Given this list of marker genes ZNF629, ERP44, UBXN2B, POP4, ZNF623, KIAA0753, GRM2, NDUFB6, NOL4, ASMTL, SAPCD1, XCL1, DUSP1, PDPN, RALGAPB, PSMA7, TNFAIP1, PEG10 (NCBI Gene Id 651242), UPK3A, COMT, PRKCH, RHBDD3, HLCS, RFXAP, LILRB2, RLIG1, RRAS2, NDUFS6 (NCBI Gene Id 4726), CEACAM7, GPSM3, ZFP36 (NCBI Gene Id 7538), DNAH17, GAPVD1, DOT1L, SRP9, RHOG, MUC6, COQ2, ATP5PO, BBC3, MFN2, FKTN, HMGB2, CNPY3, ATP5MJ, RPL13P5, FGF1, PBX2 (NCBI Gene Id 5089), LDHB, OVOL2, ATXN3, MSX2, GLRA2, PTPRN2, PRDX2, MCAT, IMPA2, ZNF271P, GLMN, NUP133, NDUFB1, TMPRSS11D, IQSEC2, CRYAA, STEAP1, HDAC2, SLC35A2, APOBEC3B, DOK5, CDK18, CKAP5, PTPRCAP, GNRH2, SLC26A10P, ARHGAP5, HNRNPM, MUC5B, IFT25, CTRC, PYGM, ASB9, CILK1, DGAT1, ORC2, PLS3, OVOL3, RAC3, RAP1GDS1 (NCBI Gene Id 5910), FUT1, RAG2, FMO5, H3C4, MYO6, ZNF92, MIR124-1HG, FLRT1, CAPN15, SPAG1, GOLIM4, RIDA, ALB, STOM, KRT31, SLC4A7, PLPP2, DLEC1, IRAK3, GUCY2D, FDPS, APOBEC3F, ZNF41, KRT34, KTN1, CUL4B, INPP4B, AIF1 (allograft inflammatory factor 1), LMO2, SMARCA5, TSC22D3, HSD11B2, BTN3A1 (NCBI Gene Id 11119), PLCH1, POU3F2 (POU class 3 homeobox 2), GPR15, TGIF2, CLASP1, AMHR2, IMPDH2, H1-2, TPM1, ANAPC5, ZNF142, RAB31, GIP, RGS2, CD1D, NAP1L3, HERC4, MAPT, RBMX2, SEPTIN11, DCBLD2, KCNF1, RUSC1, SELENOW, EFNB3, CTNNB1, USP34 (ubiquitin specific peptidase 34, NCBI Gene Id 9736), CCL19 (C-C motif chemokine ligand 19), SREK1, RIN2, APRT, NFE2L3, GPA33, CREB1, ARR3, ITSN1, PRRC2B, ZYX, DRG1, BUB1B, CSRP1, PRKACB, ARL1, PREPL, PEMT, PPARD, PPT2, EBP, SPINK4, UTP18, PIAS4, PPP2R5B, RHOBTB2, TTC1, CST5, ATP5PD, PRODH, RAD51B, FOS, CD163, SNRPE, SNTB2, CELF2, DLG2, GLIPR1, DHCR7, PADI2, SLC16A4, CTRB2, FADS2, FCGR3A, PLXND1, NIPSNAP1, RCHY1, SAMM50, IL13RA1, ZNF177, here is a description of the gene set: from publication Chaussabel D, Semnani RT, McDowell MA, Sacks D, Sher A, Nutman TB (PMID 12663451) Genes down-regulated in comparison of macrophages exposed to L. major versus macrophages exposed to M. tuberculosis. Monocyte-derived dendritic cells (DC) and macrophages (MΦ) generated in vitro from the same individual blood donors were exposed to five different pathogens, and gene expression profiles were assessed by microarray analysis. Responses to Mycobacterium tuberculosis and to phylogenetically distinct protozoan (Leishmania major, L. donovani, Toxoplasma gondii) and helminth (Brugia malayi) parasites were examined, each of which produces chronic infections in humans yet vary considerably in the nature of the immune responses they trigger. Human Gene Set: GSE360_L_MAJOR_VS_M_TUBERCULOSIS_MAC_DN species: Homo sapiens